The following is a description of a gene set: Genes from the most frequent genomic losses and homozygous deletions in a panel of patients with lymph node negative breast cancer (NNBC). from publication Climent J, Dimitrow P, Fridlyand J, Palacios J, Siebert R, Albertson DG, Gray JW, Pinkel D, Lluch A, Martinez-Climent JA (PMID 17234794) species: Homo sapiens Human Gene Set: CLIMENT_BREAST_CANCER_COPY_NUMBER_DN Despite the recent consensus on the eligibility of adjuvant systemic therapy in patients with lymph node-negative breast cancer (NNBC) based on clinicopathologic criteria, specific biological markers are needed to predict sensitivity to the different available therapeutic options. We examined the feasibility of developing a genomic predictor of chemotherapy response and recurrence risk in 185 patients with NNBC using assembled arrays containing 2,460 bacterial artificial chromosome clones for scanning the genome for DNA copy number changes. After surgery, 90 patients received anthracycline-based chemotherapy, whereas 95 did not. Tamoxifen was administered to patients with hormone receptor-positive tumors. The association of genomic and clinicopathologic data and outcome was computed using Cox proportional hazard models and multiple testing adjustment procedures. Analysis of NNBC genomes revealed a common genomic signature. Specific DNA copy number aberrations were associated with hormonal receptor status, but not with other clinicopathologic variables. In patients treated with chemotherapy, none of the genomic changes were significantly correlated with recurrence. In patients not receiving chemotherapy, deletion of eight bacterial artificial chromosome clones clustered to chromosome 11q was independently associated with relapse (disease-free survival at 10 years+/-SE, 40%+/-14% versus 86%+/-6%; P<0.0001). The 54 patients with deletion of 11q (29%) did not present more aggressive clinicopathologic features than those without 11q loss. The adverse influence of 11q deletion on clinical outcome was confirmed in an independent validation series of 88 patients with NNBC. Our data suggests that patients with NNBC with the 11q deletion might benefit from anthracycline-based chemotherapy despite other clinical, pathologic, or genetic features. However, these initial findings should be evaluated in randomized clinical trials., and this is the list of marker genes: SOX7, PPP2R1B, CASP9, KIF13B, PDGFRL, CHRNA9, MTUS1, NRG1